The following is a description of a gene set: Reactome Pathway: Signaling by APC mutants part of: Signaling by WNT in cancer APC is a large and central component of the destruction complex, which limits signaling in the absence of WNT ligand by promoting the ubiquitin-mediated degradation of beta-catenin. APC interacts with numerous components of the destruction complex, including AXINs (AXIN1 and AXIN2), GSK3s (GSK3alpha and GSK3beta), CK1, PP2A and beta-catenin, and these interactions are critical for the phosphorylation and degradation of beta-catenin. APC is itself the target of phosphorylation and K63 ubiquitination in the absence of WNT signaling and these modifications are required for its interactions with other components of the destruction complex.<br><br>More than 85% of sporadic and hereditary colorectal tumors carry loss-of-function mutations in APC. Most of the mutations are frameshifts and result in truncated proteins that lack the SAMP motifs and the 15 and 20 aa repeats that are implicated in binding AXIN and regulating beta-catenin binding and degradation. Cancers expressing truncated APC have high levels of cytoplasmic beta-catenin and deregulated expression of WNT target genes. Approximately 15% of the colorectal tumors with wild-type APC harbor phosphodegron mutations of beta-catenin; interestingly, mutations in APC and beta-catenin are mutually exclusive events. Similar to APC-mutant tumors, beta-catenin is stabilized in these tumors and constitutive WNT target activation is detected.<br><br> studied in species Homo sapiens, and this is the list of marker genes: PPP2CA, CSNK1A1, AMER1, PPP2R5A, PPP2R5D, PPP2R5B, PPP2R5E, PPP2CB, PPP2R1A, PPP2R5C, AXIN1, GSK3B, PPP2R1B, APC